The following is a description of a gene set: Human Gene Set: GOBP_ANTIGEN_PROCESSING_AND_PRESENTATION_OF_EXOGENOUS_PEPTIDE_ANTIGEN The process in which an antigen-presenting cell expresses a peptide antigen of exogenous origin on its cell surface in association with an MHC protein complex. The peptide is typically a fragment of a larger exogenous protein which has been degraded within the cell. studied in species Homo sapiens, and this is the list of marker genes: HLA-DRB4, CLEC4A, HLA-DPA1, HLA-E, HLA-DQB1, CTSS, HLA-DRB5, HLA-DQA2, CTSE, HLA-DOA, LGMN, HLA-DRB3, CTSV, HLA-DMA, PIKFYVE, FCER1G (NCBI Gene Id 2207), FCGR2B, CTSF, HLA-DRB1, LNPEP, CTSL, HLA-DQB2, CD74, MFSD6, HLA-DOB, IFI30, HLA-DQA1, DNM2, IKBKB, HLA-A, B2M, HLA-F, TAP2, FCGR1A, HLA-DPB1, UNC93B1, TRAF6 (TNF receptor associated factor 6), CTSD, HLA-DRA, HLA-DMB, MPEG1